The following is a description of a gene set: Formation of the Early Elongation Complex species: Mus musculus Mouse Gene Set: REACTOME_FORMATION_OF_THE_EARLY_ELONGATION_COMPLEX, and this is the list of marker genes: Polr2f, Ncbp1, Gtf2h5, Ncbp2, Gtf2h1, Supt4a, Mnat1, Polr2c (polymerase (RNA) II (DNA directed) polypeptide C), Ercc2, Nelfa, Polr2i, Polr2h, Gtf2h3, Supt5, Polr2k, Nelfe, Polr2b, Polr2g, Gtf2f1 (NCBI Gene Id 98053), Ercc3, Polr2e (NCBI Gene Id 66420), Ctdp1, Gtf2h4, Gtf2f2, Gtf2h2, Polr2l, Cdk7, Polr2d, Nelfcd, Ccnh, Nelfb, Polr2a